The following is a description of a gene set: Any process that results in a change in state or activity of a cell or an organism (in terms of movement, secretion, enzyme production, gene expression, etc.) as a result of detection of, or exposure to, a hyperosmotic environment, i.e. an environment with a higher concentration of solutes than the organism or cell. Human Gene Set: GOBP_HYPEROSMOTIC_RESPONSE species: Homo sapiens, and this is the list of marker genes: LETM1, SST (somatostatin), XRCC6, EPO, YBX3, FXYD2, AQP1, WNK1, OXSR1, RCSD1, TLR3, ABCB1, SLC12A2, ERRFI1, NINJ1, PKN1, RAC1, STK39, EFHD1, NFAT5, PDPK1, AKR1B1, ICOSLG, SLC2A1, SLC25A23, ARHGEF2, TRPV4, MICU1, FBP1, WNK3